Given this list of marker genes ZDHHC2, STC1, CLVS2, LHFPL3, MAP3K2 (mitogen-activated protein kinase kinase kinase 2), MED17, RPS6KA5, AQP11, SLC18A2, BRD1, RGPD4, MAL, MED12L, FAM131B, LPP, CNTN1, ZNF736, TAFA1, KLF8, HOXD8, NCK2, FCHO2, SSH1, BMI1, DIO2, ARHGEF6, PLAUR, CD69, BOD1L1 (NCBI Gene Id 57219), RAP1A, SLC7A11, HDLBP, ITGAV, EPAS1, SAMD12, STK38L (NCBI Gene Id 23012), FBXL3, MARCHF6, VPS54, ZFPM2, ATP1B4 (NCBI Gene Id 23439), PIK3C2A, BICD1 (NCBI Gene Id 636), MTMR10, DUSP18 (dual specificity phosphatase 18), NCKAP1, CADM2, STXBP4, ZNF680, NT5C1B-RDH14, RHOA, ACTN4, NEXMIF, PRPF40A, ZBTB11, IGFL1, NUP133, ADAMTS5, SGMS1, ZNF239, ARSJ (NCBI Gene Id 79642), ADAM20, RAD50, WWP1, CHSY3 (chondroitin sulfate synthase 3), DNAJB4, PTP4A1, PROM1, DNAJC25, YOD1, CAV2, MBNL3, CDK17, ABCA1, KBTBD12, TBC1D9, TENM3, ADGRB3, SLAIN1, FAM91A1, POGLUT3, RGPD8, ELAVL4, IL17F, TRIM36, DNAI7 (NCBI Gene Id 55259), CCSER1, DMD, TRUB1, SWSAP1, CSMD3 (CUB and Sushi multiple domains 3), MED6, ATXN7L2, BRWD3, HIPK1, BHLHE41, PDS5B, EFCAB14, PDCD6IP, NBN, ACER3, CAPN10, SRSF6, VGLL3, OGFRL1, CXADR, SDHB, CLIC4, ZNF445, ACTC1, LSM8, CREBRF, NR1I2, SELENOT, LACTB, ADGRL3, RORA, STX17, CD109, AHR, FGF12, RERG, ANGPTL5, MINDY2, S1PR1, GPR155 (G protein-coupled receptor 155), ONECUT2, ZNF503, MARVELD3, MAP4K3, IGF2BP3, GPC6, IGF1, SH2D1A, ZNF326, SH3KBP1, DBR1, GK5, CEP57L1, NFE2L2, RNF138, DAP3, RAB6B, TTL (NCBI Gene Id 150465), PRDM8, CCNG2, ZSCAN12, CLK4, RWDD4, ZFPL1, STAG1, SNX1, CFAP65, HAPLN1, ANGEL2, KRAS, TVP23C, BMPR1A, CILK1, NENF, FHIT, CYTH2, MAP3K20, FBXO30, ZNF624 (zinc finger protein 624), PRP4K, ABCB5, MYO1D, ZNF770, ROBO1, MKLN1, PRELID2, CCDC80 (NCBI Gene Id 151887), NKX3-1, ATP1B1, SYNJ1, C8orf34, PGM2, NR2C1, METTL6, SOX7, SNX3, MED28, STK17B, SLC12A2, TRIM23, ERH, KLF10, MTFR1, ZNF454, LRP12, KCNA4, RNH1, ACADSB, OTUD4, CUL4A, EIF5A2, BTBD1, ACKR3, TRIM13, MAN1A1, RHOQ, MED14, GAS7, LMX1A, STAU1, CA8, CNEP1R1, DLGAP1, SLC15A5, BCOR, CAPN7 (NCBI Gene Id 26587), APPBP2, SPAG9, SMAD2, SGCE, CISD2 (NCBI Gene Id 56831), KITLG, RSF1, VPS50, HELQ, UBE3B, MLH3, SLC9A6, ABHD10, UFL1, SUPT7L, STARD13, B3GNT5, KGD4, MAL2, USP9X, COMMD3-BMI1, ANGPT2, ACSL6, GNG12, PRKG1, GAB1, LRP1B, NFAT5, NBEA, DYNC1I2, CPNE4, MCM10, SLC25A21, IL22, BNIP2, ZC3H12C, FGFR1OP2, EXO1, ZXDC, HSD11B1, MYCN, HNRNPH3, HOOK3, ANKIB1, MFSD9, ZNF471, RRP15, ZMYND11, C11orf71 (NCBI Gene Id 54494), TBL1XR1, ACBD5, MAGI2, ZNF831, TVP23B, CYLD, ZNF131, ETV1, PHYHIPL, APPL1, SIX4, TMEM265, DYNLT1, UBE2A, TCF21, MID2, PLEKHA3 (pleckstrin homology domain containing A3), AADAC, CEP290, UBE4A, RGPD6 (NCBI Gene Id 729540), DIAPH2, ZBTB37, CDK19, DENND1B, KNG1, ZC3H12B, TRPC4, PPP6C, UBE2D1, CCL28, PSAT1, ZCCHC14, MTCP1, HYCC1 (NCBI Gene Id 84668), TUT4, ARID2, DLG1, HSPH1, FIGN, ATP13A3, GBP5, NPAT, ASB7, IFIT5, PTPN4, GCC2, GDNF, RC3H1, SLC30A4, ADAMTS1, CIT, MCMDC2, ADIPOR2, NALF1 (NCBI Gene Id 731895), MOSPD2, TNS1, NEDD4L, SMAD5 (NCBI Gene Id 4090), AFF4, MTR, VMP1, PIK3CA, BAZ2A, CBLN4, RB1CC1, ANKRD28, GOPC, SOCS1, PAIP1, SLC24A2, FEM1C, NFX1, TOPORS, FAM199X, ZBTB20, ARID4B, CZIB, FGD6, ST8SIA1, BVES, DNAJC7, SACS, TMX3, RGPD5, PPP3R1, REST, LEPROT, ANKS1B, ALS2, GUCY1A2, LDB2 (NCBI Gene Id 9079), ZNF587, here is a description of the gene set: Genes predicted to be targets of miRBase v22 microRNA hsa-miR-142-5p in miRDB v6.0 with MirTarget v4 prediction scores > 80 (high confidence targets). Human Gene Set: MIR142_5P species: Homo sapiens from publication Chen Y, Wang X (PMID 31504780)